Given this list of marker genes KIF7, PIGA, GTPBP2, PPP1CB, BAP1, COLQ, NXN, NCAPG2, RNU4-2, TFAP2B, DVL1, BUB1B, SCN4A, CHRNG, ROR2, INPP5E, ERCC2, LAMB2, DVL3, SNRPN, WNT5A, here is a description of the gene set: Triangular mouth The presence of a triangular form of the mouth. Human Gene Set: HP_TRIANGULAR_MOUTH species: Homo sapiens